The following is a description of a gene set: Human Gene Set: GOBP_TRYPTOPHAN_TRANSPORT The directed movement of tryptophan, 2-amino-3-(1H-indol-3-yl)propanoic acid, into, out of or within a cell, or between cells, by means of some agent such as a transporter or pore. species: Homo sapiens, and this is the list of marker genes: SLC7A5, ACE2, SLC7A8, SLC36A4, SLC3A2, SLC16A10